Given this list of marker genes NRAS, MAP2K2, EGFR, KRAS, SOS1, EGF, MAPK3, CCND1, HRAS, MAP2K1, ARAF, GRB2, SOS2, BRAF (NCBI Gene Id 673), RAF1, MAPK1, here is a description of the gene set: Human Gene Set: KEGG_MEDICUS_REFERENCE_EGF_EGFR_RAS_ERK_SIGNALING_PATHWAY Pathway Definition from KEGG: EGF -> EGFR -> GRB2 -> SOS -> RAS -> RAF -> MEK -> ERK -> CCND1 EGF-EGFR-RAS-ERK signaling pathway. Pathway ID: N00001. Pathway type: Reference. Pathway class: nt06260 Colorectal cancer. species: Homo sapiens